Given this list of marker genes GRIN2D, SHQ1, USP7, CHRNE, MTMR14, COL6A2, GNB2, MAP3K7, POLR2A, KBTBD13, TMCO1, H4C3, AARS1, FGFR3, SYNGAP1, PRUNE1, ODC1, KCNB1, SLC25A1, NSD1 (NCBI Gene Id 6797), CELF2, BICD2, HACD1, KIF5C, TRAIP, FBXO28, GABBR2, DOK7, KCNA2, ATP6V1A, CNTNAP1, ATP1A2, UBA1, MYT1L, SMN1, PPP3CA, DPAGT1, IGF2, ASCC1, AP3B2, PEX3, FKBP14, ERCC5, PEX19, NDN, CHAT, MYF6, PGAP2, SLC16A2 (solute carrier family 16 member 2), CACNA1A, MAP3K20, NIPBL, TRAK1, NUP188, ALG8, KLHL41, MYCN, OCA2, PACS2, DNM1, TPM3, SCYL2, CLTC, LETM1 (leucine zipper and EF-hand containing transmembrane protein 1), DMPK, ZC4H2, SNAP25, LMOD3, CHRNG, ZMPSTE24, KCNC2, CPLX1, ACTL6B, SCN3A, GABRA5, NTRK2, KLHL40, NEK9, DNM2, SNORD116-1, SMC3, PREPL, DPH5, RIPK4, LGI4, EXOSC9, TNNC2, NSD2, HSPG2, TPM2, CLPB, COL12A1, YWHAG, CPSF3, FGFRL1, CHUK, ADGRG6, ASCL1, CAMKMT, ATP1A3, ERBB3, NFASC, TRIP4, CACNA1B, UNC45B, MEGF10, MYH3, DNM1L, WDR62 (NCBI Gene Id 4181), GBE1, CHRNA1, SLC5A7, VAMP1, PSAT1, GLE1, NPAP1, MTM1, IL2RB, SZT2, DPYSL5, AGRN, SLC25A19, MPZ, PIGG, TOR1A, ALDH7A1, FGF12, KIF21A, TSFM, NAA10, SELENON, GPKOW, SCN4A, ACTA1, ALG14, GMPPB, COL6A1, IGHMBP2, SOX10, ASNS, MYMK, SCN8A, NEB, GABRG2, FOXG1, EBF3 (EBF transcription factor 3), MYL1, CYFIP2, PARS2, MYOD1, PIGS, PWAR1, HDAC8, GLDN (NCBI Gene Id 342035), CHRND, DHCR7, BRD4, GFPT1, VPS13B, HERC2, CNTN1, PHGDH, PPM1B, NEXMIF, CTBP1, GABRB2, ITGA7, COL6A3, DHDDS, PHOX2B, PTRH2, DOCK6, TAF6, HCN1, SNRPN, SMC1A, NECAP1, SLC1A2, SLC38A3, CRELD1, ADCY6, SLC18A3, CNKSR2, DEAF1, MAGEL2, CDC42BPB, SNUPN, IQSEC2, MYO9A, NAA20, SCN1A, CACNA2D1 (calcium voltage-gated channel auxiliary subunit alpha2delta 1), MUSK, SLC13A5, GABRA2, COL13A1, NALCN (NCBI Gene Id 93074), COL25A1, PWRN1, FLII, B3GLCT, COX15, CDK19, TRPV4, TBCK, UBA5, PAX7, PLOD1, CRPPA, SNORD115-1, LMNA, GOSR2, TUBA1A, FXR1, RET, GBA1, FZR1, SYT2, DALRD3, WWOX, ALG9, CCDC174, BIN1, FILIP1, SLC25A26, RAPSN, MYL2, GGPS1, SYNE1, ZBTB42, SLC3A1, MYPN, NELFA, CCDC47, RYR1, SYNJ1, NUS1, NUP88, DNA2, RAI1, MKRN3, RAD21, PLPBP, H19 (H19, imprinted maternally expressed transcript), ERGIC1, GLRB, EEF1A2, here is a description of the gene set: Prenatal movement abnormality Human Gene Set: HP_PRENATAL_MOVEMENT_ABNORMALITY An abnormality of fetal movement. species: Homo sapiens